The following is a description of a gene set: Genes down-regulated in comparison of medullary macrophages versus subcapsular sinus (SCS) macrophages. studied in species Homo sapiens Human Gene Set: GSE15767_MED_VS_SCS_MAC_LN_DN from publication Phan TG, Green JA, Gray EE, Xu Y, Cyster JG (PMID 19503106) LN resident macrophages lining the lymphatic sinuses play critical roles in antigen capture and presentation as well as degradation. We used microarray to examine global gene expression profiles to compare SCS and med macrophages to determine the underlying molecular basis of their differential handling of antigens., and this is the list of marker genes: STMP1, PYM1, RAMP1, TASP1, CARNS1, ABHD17B, SKIC2, AKIRIN2, IP6K1, TRAF1, NDFIP1, FHIP1B, GRAP2, FANCG, RETREG1, ANKRD63, MPPE1, PLCB4, ADGRL1, BBOF1, CD82, TMEM64, PRRT1, GALNT1, DOCK3, GPBP1L1, SMYD2, CD247, SUGT1, SEC24C, NAA10, SS18, HIVEP2, NIBAN1, RPL14, IBTK, LYSMD1, REXO2, TUBE1, JAG1 (jagged canonical Notch ligand 1), NPAS2, AKTIP, CEP170B, MAPK11, ZC3HAV1L, AAAS, SRPK1, DLG5, UIMC1, DDX46, EHD3, SH2D2A, TMEM31, MSRB2, KPNA4, AFF4, MDN1, COLGALT2, TTLL12, AQP3, IL18R1, CIBAR1, EML3, SEPTIN4, C18orf54, MAP4, PPP1R16B, STX1A, ATP13A1, PLCG1, TRPV2, CTCF (NCBI Gene Id 10664), ATN1, SMIM1, RPS5, RAVER1, GPR68, SLC25A46, MYNN, RARG, IL27RA, MPND, CBX7, TRIP11, CNST, ZDHHC18, TBC1D22B, FOXO1, SMOX, ZC3H13, NAA16, B3GALT2, UBR5, ABHD15, SELENOH, LAX1, CDK8, MYCN, ZBTB4, ROM1, MLLT6 (NCBI Gene Id 4302), ADAMTS2, SLC37A3 (solute carrier family 37 member 3), EIF3H, MOB3A, DAP, TAX1BP1 (Tax1 binding protein 1), RAB19, TRIB2, BRAP, ETS1, CORO2B, TBL1X, DKK3, MBNL3, CDON, WDR75, PHGDH, SLC9A9, SEPTIN11, WDR43, LMBR1, NXPE3, NCBP1, TNFSF10, HDAC7, HS2ST1, IFT140, PFAS, GTF2I, SAMD11, SLAMF1, NUMA1 (nuclear mitotic apparatus protein 1), CNOT2, SIPA1L1, CUL3, UNG, HACD3, TRIM24 (NCBI Gene Id 8805), NEU3, RBCK1, SETX, SLC25A23, SP4, ARNT2, JMJD4, COA6, LRRC17, PPAT, PTCH1, ITK, EI24, PABPC1L, HLF, FAH, ZNF652, TRPT1, ESRP2, DENND6B, LIME1, RWDD1, SLC7A6, SETDB2, SPN, ZDHHC2, CD8B, CLIP1, CROT, PIM2, KIAA0040, PLEKHF1, TMEM209, FARP1, FASTKD1, VPS28, LPXN, FKBP3, SIGIRR, CEP63, CYTH1, TMEM158, RPL22L1, APPL1, TRMT6, DLG3, GRAMD1A, CAP2, ITPR3, RAD54L2, IFFO2, S100PBP, ZNF580, FASN, PSIP1, IL2, ENTREP3, DNAJB2, IFT80, KRT24